The following is a description of a gene set: IL1 and megakaryocytes in obesity species: Homo sapiens Human Gene Set: WP_IL1_AND_MEGAKARYOCYTES_IN_OBESITY, and this is the list of marker genes: SELENBP1, IL1B, TIMP2, TLR1, FCER1A, MYD88, IL1R1, IRAK1, PLA2G7, NFKB1, IL18, CCL2, TLR2, MMP9, ICAM1, NLRP3, PIK3CA, HBEGF, CCR3, F2, TIMP1, IFNG, F2R, S100A9